The following is a description of a gene set: Human Gene Set: GOMF_DNA_RNA_HYBRID_BINDING species: Homo sapiens Binding to a RNA/DNA hybrid., and this is the list of marker genes: POLR3A, PRIM2, POLR3B, POLR1B, POLR1A